Given this list of marker genes CEBPG, GOSR2 (golgi SNAP receptor complex member 2), CCL2, NFYA, MBTPS2, KLHDC3, PREB, DCTN1, PLA2G4B, TLN1, PPP2R5B, CREB3L2, SRPRB, CREB3, WIPI1, HYOU1, HERPUD1, SEC31A, EIF2S2, CEBPB, EXOSC7, GSK3A, CTDSP2, ATF6, HDGF, TATDN2, EIF2S3, ZBTB17, CREB3L3, SULT1A3, ACADVL, EXOSC5, DCP2, CUL7, EXOSC2, EXTL2, TSPYL2, KDELR3, MBTPS1 (membrane bound transcription factor peptidase, site 1), FKBP14, EXOSC4 (exosome component 4), XBP1, SRPRA, EXOSC8, NFYC, ADD1, ATF6B, YIF1A, PDIA6, WFS1, EXOSC6, ARFGAP1, EXTL3, LMNA, ERN1, DNAJB9, DNAJB11, EIF2AK3, DDX11, CREB3L4, NFYB, CXXC1, SHC1, CREBRF, DIS3, DNAJC3, ATF4, SSR1, PDIA5 (NCBI Gene Id 10954), IGFBP1, EXTL1, HSP90B1, CXCL8, CREB3L1, EIF2S1, EXOSC1, GFPT1, HSPA5, PARN, DCSTAMP, TPP1, EDEM1, SERP1, ASNS (asparagine synthetase (glutamine-hydrolyzing)), EXOSC9, ATP6V0D1 (NCBI Gene Id 9114), SYVN1, CALR, EXOSC3, KHSRP (NCBI Gene Id 8570), MYDGF, DDIT3, ATF3, here is a description of the gene set: species: Homo sapiens Human Gene Set: REACTOME_UNFOLDED_PROTEIN_RESPONSE_UPR Unfolded Protein Response (UPR)